Given this list of marker genes DTX4, KCTD11, NOP56, HDAC1, TGFB1, TNFAIP2, LTB, IL1RN, UBE2F, LSS, SUB1, NOMO1, PLEK2, PRPF31, OSGIN2, CSF2, TJP2, LGALS7, HEMK1, PRIMA1, SLC35G6, SSR2, PILRB, MMP13, NCOA5, JMJD6, SBDS, CCT3, SOCS1, ZMIZ2, EPS15L1, SLC22A5, KDELR3, RANBP2, URB2, SDE2, DEPP1, SNUPN, EIF6, LRP8, FBRS, IRF7, YIF1A, WDR12, TRAF5, CX3CL1, PROCR, HACD1 (3-hydroxyacyl-CoA dehydratase 1), MAP4, MYRIP, ZCCHC2, FDFT1, TENT4A (terminal nucleotidyltransferase 4A), IDI1, NABP1, PPP1R14B, ABCC1, KDM1B, ASAP1, SIN3B, PPP2R2A, SLFN13, ATP5MG, PCP4, NCKAP1 (NCBI Gene Id 9864), DOT1L, CLRN3, UPP1, DDX18, SF3B3, ARG2 (arginase 2), IGLON5, RGL1, AARS1, NOP58, GRAMD1A, RANBP1, MSN, PXDC1, ERH, DHX15, DDX24, CHST10, NME1, H1-10 (NCBI Gene Id 8971), ACTN1, TAF10, SPRYD7, NOL11, TJAP1, GRAMD1B, ACBD3, KRT82, ABRACL, EML4, ADAM23, AXL, AARD, PTPN4, GRHL1, MYD88, ZPR1, ISG20, AK4, TOP1, EXOSC3, B3GALT6, SERINC2, CASP7, HSPA9, TASOR2, PNRC1, DNAJA2, IFT57 (intraflagellar transport 57), GAL3ST1, TIMM8A, FILIP1L, SERTAD1, VCL, CASS4, ZIM2, AEN, ABITRAM, FBL, HVCN1, IPPK, S100A6, ZNF598, ZNF507, UBL4A (NCBI Gene Id 8266), METTL2B, STBD1, FMNL2 (NCBI Gene Id 114793), GPR183, PRPS1, ARMC6 (NCBI Gene Id 93436), QTRT1, RELA, RHOB, ZNF81, CDC34, IFNG, FDPS, RWDD1, PSME1, LTF, PLEKHO2, THSD7A, ABHD17C, RMDN3, B4GALT5, CCNYL1, FNDC3A, DDX27, AGGF1, TRAF2, AGRN, COL27A1, PPAN, SLAMF8, DUSP14, EIF5, CALHM6, URB1, SERPINB2 (serpin family B member 2), RIOK2, TIMM9, GMPPB, GNB4, CD209, MAP7, SLC12A4, OASL (NCBI Gene Id 8638), ATP2A2, MAPRE1, SRM, MTDH, DIAPH1, RCC1L, PRDM2, MAPK1IP1L, PARP9, TAF4B, COX17, PSME2, LAD1, PHF6, ODC1, RXYLT1, CRELD2, CLN5, TLR5, DNAJB5, ZBTB17, CISD3, STIM2, CCDC38, UTP4, YIF1B, here is a description of the gene set: from publication Min L, Isa SA, Fam WN, Sze SK, Beretta O, Mortellaro A, Ruedl C (PMID 22250091) species: Homo sapiens Genes down-regulated in bone marrow-derived dendritic cells: unstimulated versus CSF2. A simultaneous engagement of different pathogen recognition receptors provides a tailor made adaptive immunity for an efficient defence against distinct pathogens. For example, cross talk of TLR and c-type lectin signalling effectively shapes distinct gene expression patterns by integrating the signals at the level of NF-κB. Here, we extend this principle to a strong synergism between the Dectin-1 agonist, curdlan, and an inflammatory growth factor, GM-CSF. Both together act in synergy in inducing a strong inflammatory signature which converts immature DCs to potent effector DCs. A variety of cytokines (IL-1β, IL-6, TNF-α, IL-2 and IL-12p70), costimulatory molecules (CD80, CD86, CD40 and CD70), chemokines (CxCl1, CxCl2, CxCl3, CCl12, CCl17) as well as receptors and molecules involved in fugal recognition and immunity such as Mincle, Dectin-1, Dectin-2 and Pentraxin 3 are strongly up-regulated in DC treated simultaneously with curdlan and GM-CSF. The synergistic effect of both stimuli resulted in strong IKBα phosphorylation, in its rapid degradation and in enhanced nuclear translocation of all NF-κB subunits. We further identified MAPK ERK, as one possible integration site of both signals, since its phosphorylation was clearly augmented when curdlan was co-applied with GM-CSF. Our data demonstrate that the immunomodulatory activity of curdlan requires an additional signal provided by GM-CSF to successfully initiate a robust β-glucan specific cytokine and chemokine response. The integration of both signals clearly prime and tailor a more effective innate and adaptive response against invading microbes and fungi. Human Gene Set: GSE32986_UNSTIM_VS_GMCSF_STIM_DC_DN